The following is a description of a gene set: Mouse Gene Set: GOBP_REGULATION_OF_CARDIAC_MUSCLE_CELL_MEMBRANE_REPOLARIZATION Any process that modulates the establishment or extent of a change in membrane potential in the polarizing direction towards the resting potential in a cardiomyocyte. species: Mus musculus, and this is the list of marker genes: Flna, Ank2, Rnf207, Scn5a, Kcnh6, Cacna2d1, Gja5, Kcne4, Zmpste24, Kcna5, Scn4b, Cacna1d, Akap9, Nos1ap, Snta1, Kcnq1, Cav3, Kcne2, Kcne5, Scn1b, Wdr1, Gja1, Kcnh2, Kcne3, Nppa, Kcne1